Given this list of marker genes Hcar2, Rab11fip3, Pparg, Rab11fip1, C1qtnf3, Il1b, Rab11fip5, here is a description of the gene set: Any process that modulates the frequency, rate or extent of the regulated release of adiponectin from a cell. species: Mus musculus Mouse Gene Set: GOBP_REGULATION_OF_ADIPONECTIN_SECRETION